Given this list of marker genes AQP3, PAX9, TACSTD2, KRT13, CLCA2, CARD14, SERPINB10 (serpin family B member 10), TCN1, GJB3, SFN, NECTIN1, GALNT14, KRT16, KRT6A, A2ML1, DSG1-AS1, CAPN14, PCP4L1, TP63, TMPRSS11B, S100A9, KRT4, KRT17, GPR87, S100A2, DLK2, SERPINB5, SERPINB2, TMPRSS11A, PKP1, UPK1A, FAM83C, ZNF750, LYPD3, JMJD7, KRT5, SERPINB13, KRT6B, TMPRSS11BNL, ADH7, COL17A1, GBP6, DSG3, TNS4, RHOV, TMEM40, SPRR3, FAT2, KRT6C, FGFBP1, NECTIN4, GJB6, LINC01644, LY6D, SPINK5, CALML5, S100A3, PLEKHN1, CALML3, KRT15, APOBEC3A, SCNN1B (NCBI Gene Id 6338), CYP11A1, NMU, CAPNS2, FOXN1, here is a description of the gene set: Human Gene Set: DESCARTES_FETAL_STOMACH_SQUAMOUS_EPITHELIAL_CELLS Marker genes curated from the annotated cluster as represented in the Descartes Human Gene Expression During Development database. The gene expression program underlying the specification of human cell types is of fundamental interest. The study authors generated human cell atlases of gene expression and chromatin accessibility in fetal tissues. For gene expression, the study authors applied three-level combinatorial indexing to >110 samples representing 15 organs, ultimately profiling ~4 million single cells. The study authors leveraged the literature and other atlases to identify and annotate hundreds of cell types and subtypes, both within and across tissues. Our analyses focused on organ-specific specializations of broadly distributed cell types (such as blood, endothelial, and epithelial), sites of fetal erythropoiesis (which notably included the adrenal gland), and integration with mouse developmental atlases (such as conserved specification of blood cells). These data represent a rich resource for the exploration of in vivo human gene expression in diverse tissues and cell types. from publication Cao J, O'Day DR, Pliner HA, Kingsley PD, Deng M, Daza RM, Zager MA, Aldinger KA, Blecher-Gonen R, Zhang F, Spielmann M, Palis J, Doherty D, Steemers FJ, Glass IA, Trapnell C, Shendure J (PMID 33184181) studied in species Homo sapiens